Given this list of marker genes Syt4, Cpne3, Cpne2, Anxa8, C2cd5, Syt17, Esyt1, Sytl3, Pla2g4e, Syt1, Rph3a, Cpne5, Esyt2 (NCBI Gene Id 74047), Anxa7, Syt6, Pla2g4c, Esyt3, Syt14, Cpne6, Syt8, Syt15, Syt9, Pla2g4f, Anxa5, Cpne1, Cpne4, Syt5, Anxa9, Mctp2 (multiple C2 domains, transmembrane 2), Pla2g4d, Cpne7, Anxa6, Syt3, Pclo, Pla2g4a, Pla2g4b (phospholipase A2, group IVB (cytosolic)), Syt7, Syt16, Anxa1, Syt2, Dysf, Anxa2, Anxa13, Syt10 (NCBI Gene Id 54526), Anxa4, Cpne8, Anxa3, Syt11, Plcd1, Doc2a, Anxa10, Cpne9, Doc2b, Anxa11, Syt13, Syt12, here is a description of the gene set: Binding to a phospholipid, a class of lipids containing phosphoric acid as a mono- or diester, in the presence of calcium. species: Mus musculus Mouse Gene Set: GOMF_CALCIUM_DEPENDENT_PHOSPHOLIPID_BINDING